The following is a description of a gene set: species: Mus musculus from publication Bruins W, Bruning O, Jonker MJ, Zwart E, van der Hoeven TV, Pennings JL, Rauwerda H, de Vries A, Breit TM (PMID 18195040) Human Gene Set: BRUINS_UVC_RESPONSE_EARLY_LATE Early-late response genes: differentially expressed in the first 3 h and after 12 h following UV-C irradiation of MEF cells (embryonic fibroblast). Phosphorylation is important in p53-mediated DNA damage responses. After UV irradiation, p53 is phosphorylated specifically at murine residue Ser389. Phosphorylation mutant p53.S389A cells and mice show reduced apoptosis and compromised tumor suppression after UV irradiation. We investigated the underlying cellular processes by time-series analysis of UV-induced gene expression responses in wild-type, p53.S389A, and p53(-/-) mouse embryonic fibroblasts. The absence of p53.S389 phosphorylation already causes small endogenous gene expression changes for 2,253, mostly p53-dependent, genes. These genes showed basal gene expression levels intermediate to the wild type and p53(-/-), possibly to readjust the p53 network. Overall, the p53.S389A mutation lifts p53-dependent gene repression to a level similar to that of p53(-/-) but has lesser effect on p53-dependently induced genes. In the wild type, the response of genes to UV irradiation was strictly biphasic. The early stress response, from 0 to 3 h, results in the activation of processes to prevent the accumulation of DNA damage in cells, whereas the late response, from 12 to 24 h, relates more to reentering the cell cycle. Although the p53.S389A UV gene response was only subtly changed, many cellular processes were significantly affected. The early response was affected the most, and many cellular processes were phase-specifically lost, gained, or altered, e.g., induction of apoptosis, cell division, and DNA repair, respectively. Altogether, p53.S389 phosphorylation seems essential for many p53 target genes and p53-dependent processes., and this is the list of marker genes: TAFAZZIN, C16orf95, MAT2B, STAMBPL1, NEB, NDFIP2, SMC6, CAMKK1, DGAT1, SSB, SMURF2, CDT1, GPX3, UIMC1, NME4, TRAF2, RMDN3 (NCBI Gene Id 55177), RLIG1, CTDP1, ETV5, HAS2, RNF115, KCNK2, CALD1, EPC1, PTPN2, PUM1, TUFT1, NR2C1, FILIP1L, HNRNPLL, TRBV13, GUCY1B2, CLPP, SNORD55, FBXO5, E2F3, LRR1, IRGM, CASP8AP2, TULP3, TINF2, MAP2, SNX10, PLCD3, SOCS3, UBE2W, GPCPD1, ZMYND8, RASSF5, DNAAF2, BANF1, RPLP0, APOBEC1, ARL6IP6, ECT2, CDC40, PPP1R15B, RBM38, CRTC3, ARHGDIG, HDAC9, ACVR1, MSRB2, ABCD3, LSM1, EMSY, P2RY12, SLC30A6, KPNA3, RAD18, RPP21, SLC1A2, CHD2, SNHG9, FRMD4A, USF2, LPCAT1, LNX2, MAP1A, TMEM223 (transmembrane protein 223), NASP, DDHD1, ATRX, STX17 (syntaxin 17), NUP37, SPRY2, CALM3, NMNAT3, SKA2, RRAS2, ACTRT3, ARIH1, PIK3CB, PTER, STAG2, CLN8, WAC, ATOH8, UVSSA, CSTF3, LRP1, RPS20, PSMC6, IFRD1, COL6A4P1, CHORDC1, VPS37B, MVB12B, APLP1, LMBRD1, CTDSPL, SIX3, TUBD1, MOB4, GRIK2, PPP1R11, YJU2B, DLG3, TMEM88, EIF3A (eukaryotic translation initiation factor 3 subunit A), RMND1, CYP26A1, ANAPC15, SRRM2, CCNE2, FAF2, PSMG2, FAM228A, ASAP1, CEMIP, AHRR, FBXW11, ZNF281, DENND1B, SMAP1 (NCBI Gene Id 648324), MTA3, RORA, DUSP12, RPSA, ACTR8, PMFBP1, RNF216, PTPN12, PDZRN3, PLAT, ATG3, ARID1A, LRIG1, NAT8, POU2F2, QKI, DUSP14, PKP2 (NCBI Gene Id 93271), DHX33, IGF1R, MLH3, SLC4A1AP, CCDC124, NOSIP, IFT27, C19orf48P, INSIG2, DYRK2, AKIRIN2, ZBTB25, TRIM6, STING1, NENF, FOXK2, ANXA3 (annexin A3), PPP2R2D, C8B, SEC22A, NSMCE3, MYCL, TOM1L1, MED10, FUBP1 (NCBI Gene Id 8880), DTWD1, CES2, AUNIP, CD84, UBE2G1, EXO1, SMC3, LLCFC1, DUSP16, HSPBP1 (HSPA (Hsp70) binding protein 1), NXPH3, MVD, ZFAND1, RILPL1, STK10, PGM2, C5orf63, MACROD2, ULBP1, PRDM5, SLIT1, ASPSCR1, NTF3, CDYL, DESI2, EBAG9, FES, UBN1, SEMA6C, RAB25 (NCBI Gene Id 57111), KCMF1, SNX24 (sorting nexin 24), TOR4A, EXOSC7, SLX4IP, SORBS1, CHCHD6, C3orf62, TCEANC2, FRA10AC1, SPTLC2, GMNN, FBXO42, MITD1, TRAPPC2, GAS8, KCNE3, TXNDC16, SMAD6, RNF111 (NCBI Gene Id 54778), CTRC, MAP4, CCDC6, SNHG20, ABRAXAS1, SEC24B, UBLCP1, EVPL, TRIM26, RPS17, TREX1, NUDT7 (NCBI Gene Id 730766), ANKRD11 (ankyrin repeat domain containing 11), PMVK, TGFBRAP1, MACROD1, FERRY3, NIPBL (NIPBL cohesin loading factor), MTIF2, TBX15, RAB3IP, SGCG, ZNRD2, AATK, C16orf87, TADA2A, AHNAK, INTS3, SPEF1, SHMT2, PPM1F, C9orf85, NECTIN2, HCFC2, PCGF6, MICOS13, TMEM248, TTN, TCP10L, NIP7, MSANTD3, STIL, UBL4A, WDSUB1, PRICKLE2, EPHA4, B9D1, TUBB4B, SS18, CISH, ZCCHC8, ALKBH8, YAF2, GFRA4, SNAP23, ZCCHC14, ZC3HC1, BCAR3 (BCAR3 adaptor protein, NSP family member), URM1, EIF1AY, GFI1, RBM6, THUMPD2, PHF3, ZBTB4, ARHGEF18, PINX1, EMC9, DUSP28, SIVA1, E2F6, OSBPL6, ZC3H6 (zinc finger CCCH-type containing 6), RND3, TGDS, POLR1HASP, TCL1B, APLF, CAMK2N2, NCOA6, BRME1, KDM1A, SCHIP1, CXCR6, MAPK1, UNC80, PTCD2